The following is a description of a gene set: Mouse Gene Set: GOBP_NEGATIVE_REGULATION_OF_PROTEIN_LOCALIZATION Any process that stops, prevents or reduces the frequency, rate or extent of a protein localization. studied in species Mus musculus, and this is the list of marker genes: Abhd17b, Snx12, Lrrc15, Hnf4a, Ttbk2, Wnk3 (NCBI Gene Id 546388), Fkbp1b, Ankrd13a, Jagn1, Sergef, Bag4 (BCL2-associated athanogene 4), Ins1, Ogt, Ngdn, Astn2, Inpp5e, Syt4, Mup2, Cltc, Ptpn11, Sumo1, Inpp5k (inositol polyphosphate 5-phosphatase K), Ifnb1, Rab11fip3, Srcin1, Erp29, Cdkn2a, Map4k4, Lzts2, Tmem59, Angpt1, Nos1, Rptor, Il12a, Pid1 (NCBI Gene Id 98496), Gnao1, Ilrun, Gdi1, Kcnb1, Snx33, Lilrb4a, Mup11, Cd36, Cyp51, 4930550C14Rik, Ffar2, Pde8b, Neo1, Mup3, Drd3, Eny2, Drd4, Ube2g2 (ubiquitin-conjugating enzyme E2G 2), Mdfic, Ywhab, Rest, Mapt, Commd1 (COMM domain containing 1), Gnaz, Inhbb, Pkig, Crhr2, Drd2, Ppm1f, Rock2, Lrrk2, Kcnj11, Derl2 (Der1-like domain family, member 2), Gopc, Psmd9, Kcne1, Mtnr1b, Tmbim1, Adtrp, Sirt4, Ppfia1, Klf7, Rhoq, Ptpmt1, Anxa5, Apod, Pias4, Gripap1, Sirt1, Maged1, Akt1, Rangap1, Cdk9, Bag3, Tbc1d1, Kcnj6, Bcl2l1, Usp17le, Rsad2, Map1a, Pde4c, Trp53inp2, Tmed2, Cldn18, Ndufaf2, Mup5, Dmtn, Npff, Siah3, Plk2, Abi3, Mtor, Naca, Sytl4, Pde3b, Il12b, Trim29, Ghrl, Adra2a, Nf1, Vsnl1, Rhbdf1, Abhd17a, Mup4, Cabp1, Numb, Foxo1 (forkhead box O1), Ctnna1, Sirt6, Lats2, Lypd1, Mfhas1, Chga, Nfkbia, Sp100, Wnk4, Gbp4, Sapcd2, Trim40, Ywhaz, Spi1, Nr1h3, Ubac2, Prkn, Erlec1, Dclk3, Hdac3, Rab23, Ccn3, Actn2, Txn1, Tgfb1, Ppp3ca, Sfrp1, Picalm (NCBI Gene Id 233489), Fzd9, Rab11fip1, Ndfip1, Pkdcc (NCBI Gene Id 13934), Chp1, Insig1, Ucp2, Idh2, Il1b, Nedd4l, Abcc8, Fam76b, App, Ins2, Kcnq1, Ghsr, Hectd1, Frmd4a, Park7, Snx3, Terf1, Ffar3, Mtnr1a, Svip (NCBI Gene Id 75744), Lyplal1, Ube2j1, Cd200, Mrap2, Gnai1, Anxa1, Tax1bp3, Ptger3, Apoe, Dph3, Idua, Btf3, Rab11fip5, Polr1a, Fbn1, Ripor2, Acvr1c, Gdi2, Midn, Akap1, Oprm1, Ppp2r5a, Abhd17c, Stxbp5l, Dclk1, Pkia, Wwp2, Nol3, Itgb1bp1, Mrap, Dnaja1, Sin3a, Fam3d, Fermt1, F2r, Coro2b, Cdh1, Wnk1, Pim3, Ei24, Mark3, Csk, Rnf4, Tmem98, Dclk2, Ptprv, Gpm6b, Vps35, Hmgcr, Uts2, Ubxn2b, Os9 (amplified in osteosarcoma), Fbxo4, Gsk3b, Srebf1, Sfn, Yod1, Irs1, Lilrb4b, Lats1, Lztfl1, Dab2, Pfkl, Nsfl1c, Madd, Ufm1, Otud7b, Pde1c, Adipoq, F2rl1, Mup1, Ndfip2, Derl3, Rhbdf2, Arf6, Ap2m1, Macroh2a1, Hadh, Leprot (leptin receptor overlapping transcript), Vcp, Lypla1 (NCBI Gene Id 18777), Bard1, Cdk5